Given this list of marker genes USP8, ZBTB20, POLR3A, EIF5A, AARS1, KRT25, BICRA, MPLKIP, ATR, RNU4ATAC, ITGA3, RECQL4, CARS1, RPL21, DCLRE1B, OCRL, GTF2E2, CENPE, PLK4, SMARCE1, KIFBP, CST6, KDM1A, LTV1 (NCBI Gene Id 84946), DPF2 (NCBI Gene Id 5977), CRIPT, EPS8L3, SHOC2, TRPS1, DNA2, SPINK5, BRAF, CEP152, CDH23, CACNA1C, DPH2, GNB2, LSS, NOP10, ERCC3, KAT6B, KANK2, JUP, DSG4, SNRPE, UBR1, TERT, SOX18, ADNP, AHSG, CDC42BPB, IPO8, WNT10A, TARS1, AXIN2, FAS, ARID2, USP48, CLDN1, RNU12, UBA2, NUP85, RIPK4 (receptor interacting serine/threonine kinase 4), GJA1, NECTIN4, APCDD1 (NCBI Gene Id 85500), TINF2, SMARCC2, ARID1B, CBS (cystathionine beta-synthase), B4GALT7, TRAIP, PARN, TP63, SMARCA4 (NCBI Gene Id 6597), MBTPS2, PTPN22, DPH1, NSUN2, APC2, ARID1A, HLA-DRA, DKC1, GTF2H5, GJB6, PCGF2, SMARCA2, DSC3, SLC25A24, HRURF, HR, WLS, ATRIP, SMARCB1, RIN2, NEPRO, ERCC2, SOX4, PPP1CB, NTRK1, ITGB6, EDARADD, VAC14, IFT140, EXT1, TP53, HDAC4, CAV1, PCNT, RTEL1, NSD1, C3orf52, IGF1R, PRKD1, FIG4, TSPEAR, CDSN, LIPH, NHP2, MAF, KRT17 (NCBI Gene Id 5103), ACD, CDH3, GJB2, LMNA, B3GALT6, LPAR6, RBBP8, WRN, ODC1, LIG4, MED25, BANF1, NFKBIA, NR3C1, PPP1R13L, RAD21, SMARCD1, RNF113A, ATRX, SOX11, KRT74, here is a description of the gene set: Decreased number of hairs per unit area of skin of the scalp. species: Homo sapiens Sparse scalp hair Human Gene Set: HP_SPARSE_SCALP_HAIR